Given this list of marker genes ARAF, PRKCB, BRAF, EGFR, PLCG2, MAP2K1, PLCG1, MAPK1, PRKCG, RAF1, MAPK3, PRKCA, MAP2K2, CCND1 (NCBI Gene Id 893), here is a description of the gene set: Mutation-activated EGFR to PLCG-ERK signaling pathway. Pathway ID: N00024. Pathway type: Variant. Pathway class: nt06266 Non-small cell lung cancer. Pathway Definition from KEGG: EGFR* -> PLCG -> IP3 -> (Ca2+,DAG) -> PKC -> RAF -> MEK -> ERK -> CCND1 species: Homo sapiens Human Gene Set: KEGG_MEDICUS_VARIANT_MUTATION_ACTIVATED_EGFR_TO_PLCG_ERK_SIGNALING_PATHWAY